The following is a description of a gene set: Human Gene Set: WP_CILIOPATHIES Ciliopathies studied in species Homo sapiens, and this is the list of marker genes: BBS10, CEP19, SUFU, GLI3, HYDIN, TAPT1, SMO (NCBI Gene Id 6608), CEP41, PKD1L1, RP2, DNAAF4, BBS9, PIK3R4, CCDC103, TCTN1, IFT52, BBS5, DNAH11, DNAI2, ANKS6, PKD1, CCDC40, TRIM32, GLI2, ODAD3, BBS7, AHI1, CFAP418, AK7, GLIS2 (NCBI Gene Id 84662), SPATA7, CEP164, FAM161A, CNGA1, GAS8, USP9X, NEK1, RSPH1, CFAP298, IFT27, CSPP1, CC2D2A, ZIC2, DDX59, SCLT1, KIAA0586, OCRL, DYNC2I2, CENPF, KIZ, RSPH4A, NPHP1, BBS4 (NCBI Gene Id 585), IFT81, TUB, TULP1, CEP104, IFT43, BBIP1, TTBK2, DNAL1, TTC8, ZNF423, EFHC1, DNAAF11, IFT122, CFAP53, LZTFL1, DYNLT2B, PKHD1, NPHP4, DNAAF6, RPGRIP1, CCNQ, ADCY6 (adenylate cyclase 6), CLUAP1 (clusterin associated protein 1), DNAJB13, ODAD2, IFT140, RP1L1, CRX, IQCB1 (IQ motif containing B1), DRC1, PKD2, SDCCAG8, TMEM17, B9D2, TOPORS, KIF7, NEK2, POC1A, LCA5, CCDC39, NME7, ALMS1, BBS12, TMEM237, TMEM67, INPP5E, HYLS1, NPHP3, ANKS3, INTU, TMEM107, TTLL5, RP1 (NCBI Gene Id 6101), TTC21B, EVC2, NEK8, PIBF1, NME9, C2CD3, CFAP410, KIAA0753, CEP83, ARL13B, IFT80, CEP78, ODAD1, DNAAF3, RPGRIP1L, WDR35, ARL2BP, TBC1D32, BBS1, DNAAF5, DYNC2LI1, DNAI1, TRAF3IP1, CCDC65, MAK, DYNC2I1, NEK9, IFT57, RAB23, KATNIP, GALNT11, DNAH6, TCTN3, TMEM138, PCARE, MKKS, CILK1, MCIDAS, TCTN2, RSPH9, XPNPEP3, CEP120, ARL3, POC1B, CCNO, OFD1, CEP290, ATXN10, IFT172, FLCN, DNAAF1 (NCBI Gene Id 123872), RAB28, WDPCP, PLK4, ODAD4, INVS, RSPH3, ARL6, EVC, GPR161, TMEM231, SPAG1, UNC119, CPLANE1, ZMYND10, PDE6D, TMEM216, WDR19, BBS2, CCDC28B, CNGB1 (NCBI Gene Id 1258), DNAAF2, B9D1, CFAP52 (cilia and flagella associated protein 52), DCDC2, MKS1, POMGNT1, DYNC2H1